Given this list of marker genes DENR, NFKB2, SPSB1, TXN, IL15RA, PTPN2, TIMMDC1 (translocase of inner mitochondrial membrane domain containing 1), NINJ1, ADA, IL7R, TGFA, SMPX, RELB (NCBI Gene Id 5971), CPM, LSS (NCBI Gene Id 4047), LAG3, DNAJC3, SLAMF1, MIR22HG, LILRA1, HLA-DOA, SEC61B, LIMK2, GRK6, NPPB, CYP27B1, LANCL1, CTTNBP2NL, TRIP10, PTPN1, HLX, LGALS3, GRAMD1A, ITGB3, here is a description of the gene set: studied in species Homo sapiens Human Gene Set: MODULE_522 Immune response genes.